The following is a description of a gene set: studied in species Mus musculus The intramolecular conversion of uridine to pseudouridine in an rRNA molecule during ribosome biogenesis using a snoRNA guide that targets the position of pseudouridylation. Mouse Gene Set: GOBP_SNORNA_GUIDED_RRNA_PSEUDOURIDINE_SYNTHESIS, and this is the list of marker genes: Nhp2, Nop10, Naf1, Gar1, Dkc1